The following is a description of a gene set: Human Gene Set: MIR6796_3P from publication Chen Y, Wang X (PMID 31504780) species: Homo sapiens Genes predicted to be targets of miRBase v22 microRNA hsa-miR-6796-3p in miRDB v6.0 with MirTarget v4 prediction scores > 80 (high confidence targets)., and this is the list of marker genes: NOVA1, SEC24A, GPATCH2L (NCBI Gene Id 82392), MTFR2, BBS7, MACF1, PCDH19, HSPA4L, SERPINF1, PANK1, RCAN2, GALNT15, TRABD2B, HERPUD1, PIAS2, WHRN, RSBN1L, LHCGR, TRIM32, CANX, COLEC12, PTPMT1, ZBTB10, ZBTB33, CPD, SULT4A1, SLC2A12, DMD, NFATC3, ZNF189, TET3, PDE4D, PYGL, CEP83, USP9X, KRT12, TOX4, IFT57, RAB11FIP5, FBXL15, WDR26, MCM4, TVP23B, SPRED1, NCKAP1L, TVP23C, FAM117A, OTUD7B, UBE2E2, CBL, PHF3, GNG2, TMEM59, NF2, CERS5, SRI, RAB2A, FIGN, TTLL1, FNIP2